Given this list of marker genes TFR2, STEAP3, HFE, HJV, SKIC3, HAMP, BCS1L, PIGA, SLC11A2, PKLR, RACGAP1, KIF23, BMP2, FTH1, here is a description of the gene set: Increased circulating iron concentration The concentration of iron in the blood circulation is above the upper limit of normal. species: Homo sapiens Human Gene Set: HP_INCREASED_CIRCULATING_IRON_CONCENTRATION